Given this list of marker genes KLHL36, PNN, AFF4, LCP2, APBB1IP (NCBI Gene Id 54518), RGS5, ORMDL2, LAMTOR3, HGSNAT, FBXO22, TUBB2A, IER5, CRLF2, MRPS14, PHB2, JAGN1, NUP62, SELENOS, SHC1, GPR137B, TMEM165, FCHO1, RFFL, SRD5A3, ARF3, GPR155, COL26A1, NOSIP, IL1RAP, ADORA2A, TAF1C, GUCD1, HOXA3, VCP, TPP2, ACADVL, HSPA1B, SMIM7, FIS1, SPRYD3, H2AX, MFSD5, EGLN2, ALAS1, CD247, CREB3L4, ATF2, WDR45B, AOAH, DMAC1, SNX18, MEMO1, PDE8A, PLEC (plectin), SSTR3, PHF12, CCT8, MRPL44, PAFAH1B1, MAPK8, AAMP, MMACHC, SBNO1, STEAP1, KIAA0319L, MBD3, KICS2, ADSS2, HACD3, ZNF638, RILPL2, TMEM39A, HDAC2, KDM4B, CTNND1, NGRN, ASAP1, C18orf32, CREBZF, LFNG, LMBRD1, EIF1AX, FYB1, E2F4, ACLY (ATP citrate lyase), NOP10, ATOSB (NCBI Gene Id 80256), DPH5, DDX54, CAMSAP1, RANBP3, ESRRA, ACTR1A, PSMC6, LSS, QSOX1, CASP7 (caspase 7), DDOST, PXN, DENND4B, PWP1, RAP2A, EMC6, STYX, DYNLT3, EIF3E, IYD, APBB2, TNFRSF1B, PDCD4, MSL2, FKBPL, DHX40, SIRT2, IGSF9, CLEC10A, FASN, SURF4, EXOC8, SMOC2, IFITM10 (interferon induced transmembrane protein 10), FSCN1, ARL8B, CYP39A1, CIAO2B, WSB1, PRKAR1A, TP53RK, IFNGR2, PDZK1IP1, OLR1, SSR1, SLC4A2, ABCC1, PRPF39, SACM1L, SYK, MUSK, PDE12, MKKS, PGS1, CHMP7, USP47, RDH10, PRELP, RAB6A, TMED7, TPBG, GTF3C4, WRNIP1, SIRT7, SLC25A33, ALPG, CDK2AP1, WDR6, EDEM3 (NCBI Gene Id 87240), SIGLEC7, HRAS, NT5DC3, TIMM23, HYCC2, SEPTIN11, EIF3A, YAE1, CAB39, TRAPPC1, FN1, RBM15B, UBE3C, SWAP70, RCL1, CDV3, ZBTB11-AS1, TTL, RBM4, CD72, MRPS17, VPS29, UBE2G1, MYADM, PER1, KCTD4, NNAT, GDAP2, EIF6, LTN1, RNF145, BRAF, CPS1, DAZAP1, ATP6V1A, VTI1B, SUOX, FAM8A1, DNAJC21, JDP2, SLC44A1, DIMT1 (NCBI Gene Id 27292), PHYKPL, RALB, here is a description of the gene set: Human Gene Set: GSE17721_POLYIC_VS_PAM3CSK4_4H_BMDC_DN mouse primary BMDCs were stimulated with tlr ligands and gene expression changes were profiled on Affymetrix arrays Genes down-regulated in comparison of dendritic cells (DC) stimulated with poly(I:C) (TLR3 agonist) at 4 h versus DC cells stimulated with Pam3Csk4 (TLR1/2 agonist) at 4 h. from publication Amit I, Garber M, Chevrier N, Leite AP, Donner Y, Eisenhaure T, Guttman M, Grenier JK, Li W, Zuk O, Schubert LA, Birditt B, Shay T, Goren A, Zhang X, Smith Z, Deering R, McDonald RC, Cabili M, Bernstein BE, Rinn JL, Meissner A, Root DE, Hacohen N, Regev A (PMID 19729616) studied in species Homo sapiens